The following is a description of a gene set: NFE2L2 regulating tumorigenic genes species: Homo sapiens Human Gene Set: REACTOME_NFE2L2_REGULATING_TUMORIGENIC_GENES, and this is the list of marker genes: AREG, MAFK, BCL2L1, NOTCH1 (notch receptor 1), SP1, NFE2L2, PDGFA, EGF, EP300, CREBBP, BCL2